Given this list of marker genes TMEM14C, GOLT1A, HNRNPUL2, PRKDC (NCBI Gene Id 5591), RHOH (ras homolog family member H), SNX6, SPTLC1 (NCBI Gene Id 3302), CSE1L, DNAJA3, ENTREP3, KLF4, RCC1L, PHAX, UQCRB, PLOD3, HSD17B12 (hydroxysteroid 17-beta dehydrogenase 12, NCBI Gene Id 51144), NPEPL1, TUBD1, STK26, PPP5C, BCAR3, TRAM1, PWP2, CDKN2C, STX7, STK16, TOPORS, MTX1, PYROXD1, COMMD7, RAB7A, HSDL2, BID, CHL1, SLC35D1, GPR180, TSNAX, ZNF746, BDH1, TUBGCP3, SLC35A1, HASPIN (histone H3 associated protein kinase), RPS6KA1, PIGQ, PRMT5, LMAN2, FGFR1OP2, IPO8, IPO9, SEC22B, MCM3AP, CHMP1A (NCBI Gene Id 5642), MAP4, DOK2, STXBP6, BAG1, GLMN, CLCN7, ZDHHC4, CTDP1, PCNP, BRD4, CCDC91, COX18, SNX4, ACLY, ELMO2, OGA, ECHDC1, ORMDL2, HNRNPR, HRAS, CSTF1, MCM5, EVI5, ZBTB12, ARRB1, SMYD5, NCMAP, SLAMF6, FAM3C, HACD3, SUGP2, FKBP4, UBE4A (ubiquitination factor E4A), NUFIP1, DKKL1, LARP1, DGKZ, TMEM203, SDHA, POLDIP2, STX3, BET1, DNAJC15, STK10, CALR, SEC61A2, ATG16L1, METAP2, GNPTAB, EIF4EBP2, MRPL22, ATP6AP1, API5, NUDT4, TYW1, MBNL1, NDUFA9, SELENOT, ERMP1, GTF2H4, IREB2, PEX2, IMPACT (NCBI Gene Id 55364), RNASEL, TMEM268, CMTM3, EIF3B, GATM, VTI1B, ACSL5, DHX9, PNPO (NCBI Gene Id 55163), SDHD, ATXN7L3, ATXN10, USP5, SMARCD2, PURB, OPN3, FIZ1, MATK, TRAP1, SHH, CCR1, APRT, SEL1L, SMC4 (structural maintenance of chromosomes 4), NAAA, NUP160, ETAA1, BTBD1, YEATS4, SNX3, RNF187, UQCC1, PIP4P2, MRPL9, FLT1, VTA1, CCNQ, ANPEP, EIF2S2, THRAP3, SLC25A39, APOC3, XRCC6, CDIPTOSP, RPS6, ERAL1, EIF3E, BCCIP, SLC30A5, AGTRAP, CCND3, LCLAT1, TRIM27, P2RY1, TRAF6, COL4A6, LRRC40, PPP6C, POLR2H, PROS1, ZDHHC7, BPNT1, SF3B3, CNIH1, MMACHC (NCBI Gene Id 25974), RPL36A, GJD2 (gap junction protein delta 2), PDS5A, PDCD2, GANAB, CYB5R1, ZBTB7A, TGFBR2, COG8, EXOC8, TMEM33, PGS1, GBA1, ZFX, STOML2, TMEM183A, TXNL1, ACIN1, NPRL2, ZFP36L2, here is a description of the gene set: Human Gene Set: GSE17721_CPG_VS_GARDIQUIMOD_1H_BMDC_DN mouse primary BMDCs were stimulated with tlr ligands and gene expression changes were profiled on Affymetrix arrays from publication Amit I, Garber M, Chevrier N, Leite AP, Donner Y, Eisenhaure T, Guttman M, Grenier JK, Li W, Zuk O, Schubert LA, Birditt B, Shay T, Goren A, Zhang X, Smith Z, Deering R, McDonald RC, Cabili M, Bernstein BE, Rinn JL, Meissner A, Root DE, Hacohen N, Regev A (PMID 19729616) studied in species Homo sapiens Genes down-regulated in comparison of dendritic cells (DC) stimulated with CpG DNA (TLR9 agonist) at 1 h versus DC cells stimulated with Gardiquimod (TLR7 agonist) at 1 h.